The following is a description of a gene set: from publication Yevshin I, Sharipov R, Kolmykov S, Kondrakhin Y, Kolpakov F (PMID 30445619) Genes containing one or more binding sites for (Zfp64) in their promoter regions (TSS -1000,+100 bp) as identified by GTRD version 20.06 ChIP-seq harmonization. species: Mus musculus Mouse Gene Set: ZFP64_TARGET_GENES, and this is the list of marker genes: 4930515G01Rik, Fxn, Birc5, Mocs1, Med23, Pdk1, Gmpr2, 1810044D09Rik, Dimt1, Capn15, Ankle2, Pisd-ps2, Psmb7, Pelp1, Epb42, Foxj1, Egfl7, Dhx38, Gm11346, Pcid2, Noc4l, Gm1972, Zc3h18, Golph3, Git2, Glod4, Dxo, Ecm1, Traip, Kcnq5, Snx12, Tex9, Zzz3, Sec62, Mettl6, Zfp963, Snrk, Nup153, Tsn, Rere, Mrpl12, Cnot1, Atg4b, Plxna3, Ipo11, Ugt1a6a, Bcl7c, 4833418N02Rik (RIKEN cDNA 4833418N02 gene), Grb10, Sde2, Mylpf, Lamc1 (laminin, gamma 1), Mrps11, Zfp703, Anapc2, Slc17a5, Gm15781, Trav4-4-dv10, Ube3b, Vps11, Zfp296, Trim27, 1700034P13Rik, 3110082I17Rik, Rrp1, Mrm3, Tmppe, Rrp1b, Creld1, Tmem218, Kmt2b, Nmnat1, Zfp609, Ccne1, Dqx1, Txnl4b (NCBI Gene Id 234723), Ergic2 (ERGIC and golgi 2), Idh3b, C1ql4, Zfyve1, Rbm6, Rbmx, Cpsf1, Usp27x, Pex1, Palb2, Nfyc, Eapp, Abcf2, Plcb3 (phospholipase C, beta 3), Cab39, Polr3f, Ttpal, Capn1, U2af1, Haus1, B4galt7, Tsen34, Zfp516, Zswim6, Parp14, Mkx, Papss1, Adat2, Cyth4, Pitx3, Lck, St3gal2, Nelfa, 2610318N02Rik (RIKEN cDNA 2610318N02 gene), Fzd4 (frizzled class receptor 4), Tor1b, Pole2, Mrps22, Pdgfa, Gtf2e1, Kctd10, Sugp2, Mir6236, Prpf31, 3000002C10Rik, Dffb, Gm14455, Lias, Dnaja1, Gle1, Serp1, Nme6, Zfand2b, Ubiad1, Nup133 (NCBI Gene Id 234865), Lbh, Cdca8, Rnf217, Rnpep, Wdr89, Odr4, Osbpl1a, Timm44, 2900005J15Rik, Afap1, Smg8, Nagpa, Hsd17b8, Zc3hc1, Zfp287, P2ry14, Mcf2l (mcf.2 transforming sequence-like), Mir301b, Lzic, Sdhb, Wdr25, Fbxl3, Usp31, Thrap3, D130017N08Rik, Wdr4, Nup214, Ptp4a3, Zfyve26, Pdcl3, Wdr48, Rcbtb1, Tbccd1, Lrpprc, Cul4a, Eif2a, Spns1, Endov, Bbc3, Kbtbd8, Emc7, Atpaf2, Mir5625, Ssna1, Gm13710, Fau, Ccdc59, Cdh24, Alg2, Tomm6, Tanc1, Ptrh1 (peptidyl-tRNA hydrolase 1 homolog), Pald1, Mapk9, Kbtbd8os, Mrpl50, Scrib, Zfp710, Isg20l2 (NCBI Gene Id 97085), Bltp3a, Rlf, Slc35e1, Gngt2, Rbm48, Crnkl1, Dnajc1, Mir3569, Mrpl46, Rabl3, Prorp, AA914427, 4930477E14Rik, Wfdc3, Zng1, Copz1, Ccdc122, Catspere2, Cenpi, Uqcrfs1 (ubiquinol-cytochrome c reductase, Rieske iron-sulfur polypeptide 1), Lacc1, Eif2b1, Dnajb11, Fam76a, Vps33a, Cd151, Ube2n, Gm10575, Washc5, Epg5, Mta2, Ncbp2as2, Dtymk, Dffa, Crnde, Gm15564, Mrps9, H2-M10.5-ps1, Mapkapk5, Thbs1 (thrombospondin 1), Gm9958, Ginm1, Anapc10, Znhit3, Aco2, Pet100, Me2, Pde4a, Spryd3, Chmp4b, Glb1, Actb, Cep170, Mboat7, Gm24377, Mrps14, Gtf2h3, Nfkb2, Glis3, Rnf121, Tns1, A930012O16Rik, Gm17435, 9230114K14Rik (RIKEN cDNA 9230114K14 gene), Tyw5, Unk, Phf5a, Grk4, Mir762, Urm1, Tysnd1 (NCBI Gene Id 71767), Sap30bp, Gtf2f2, Atf7ip, Slc12a5, Trmt44, 6330549D23Rik, 1700022N22Rik, Nsmce2, Fancd2, Ap2m1, Etv4, Nin, Lcorl, Thumpd1, Zscan22, Cbl, Emc3 (ER membrane protein complex subunit 3), Gm16892, Sphk2, Rpia, Zfp189, Pgk1, Med6, Dnttip2 (deoxynucleotidyltransferase, terminal, interacting protein 2), Pde4d, Anapc13, Mettl25, Rfx1, Slc25a16, Nop14, Ankrd17, Cdk11b, Med27, Atp2a3, Ddx52, Gm4799, Esyt2, Eif3i, Mettl9, Tmx2, Gstt3, 1110038F14Rik, Snw1, Skic8, Wars1, Htra2, Iscu, U2af1l4, Kif3b, Rrm1, Atp5po, Fam161b, Rnf168, Thoc3, Tfpt, Ttc7, Rin3, Cdon, Apoe, Qrich1, Sec61b, Fbxl18 (NCBI Gene Id 231863), Zfp523, Rnf6, AA474408, Snrpc, Kmt2a, Brms1, Mir7014, Epc1, Hspe1, Rbm8a, Nfx1, Phf7, Ss18, Supv3l1, Proscos, Lad1, Gm16531 (predicted gene, 16531), Gm2449, Mrpl39, Tatdn2, Fbxw2, Hspd1, Bap1, Pex3, Cwc25, Specc1, Tmem242, Ap5s1, Gimap1, Med29, Cox18, Gm7467, Ttc17, Pnpla6, Dip2a, Fnip1, Mrpl1, Bod1, Dzank1, Cnn3, Psenen, Vps50, Cops7b, 1810024B03Rik, Egr1, Ttc16, Tarbp2, Smpd4, Cmtr1, Gm13986, Xab2, Gm9568, Sart3, Psmb2, Airim, 2810002D19Rik, Mapk8ip3, Trim32, Sys1, Maip1, Ddx51, Myo18a, Rgl2, Gm16023, Stk19, Coq6, Arl6ip6, Cyp4f13, Mgat1, Ndufs7, Stc2, Dnajc30, Pcmtd1, Prcc, Thap4, Rassf2, Sf3b6, Bud23, Dctn5, Gm11747, Gm40332, Pphln1, Ppil4, Siva1, Gid4, Repin1, Gm26654, Yars2, Cep104, Med11, Gm15535, Luc7l3, Dus1l, Kifbp, Vmn2r-ps120, Nedd8, Scyl1, P2rx3 (purinergic receptor P2X, ligand-gated ion channel, 3), Rptor (regulatory associated protein of MTOR, complex 1), Sertad2, Eif4e2, Ormdl3, Abce1 (NCBI Gene Id 96976), Prrt2, Slc35f6, Mtg1, Dnttip1, Mrpl49, Snrnp200, Kif2c, Sfswap, Prdm10, Gm12227, Mrps15, Lgals9, Bcan, Sik3, Nup58, Rpl9, Smad5, Dnajc11, Marchf6, Anks1, Lrp2, Recql5, Hepacam2, Sumf1, Paf1, Ncbp2, Prkag2, Chchd2, Atg14, Tubgcp6, Gss, H4c14, Zyg11b, Mecr, Rpl29, Dut, Cspp1, Ccnj (NCBI Gene Id 240665), Acot11, Mzt2, Gm10516, Zfp143, 4930513N10Rik, Tpr, Brca2, Gatb, Cibar1, Gm20005, Rassf4, Rpl18, Man1b1, Gm11733, Med19, Tmem234, Thtpa, Clpb, C87436, Nsfl1c, Rab40c, Abcc1, Cfap61, Rai1, Lonp1 (NCBI Gene Id 74142), Spsb3, Uap1, Rfc4, Wdsub1, Ighmbp2, Gstz1, Abi3, Mettl25b, Pagr1a, Morf4l1, Lratd2 (NCBI Gene Id 399603), Dnajc12, Ints14, Ganab, Gm19774, Nap1l4, Clock, Ranbp2, Ranbp6, Gpatch3, Psmg1, Pax5, 6720482G16Rik, Rtf2, Spart, Prpf40a, Kbtbd7, Aup1, Ess2, Rara, Zcrb1, 9430037G07Rik, Ndufb2, Caap1, Rasal1, Ube4a, 9430015G10Rik, Ubr4, U2surp, Mrpl21